The following is a description of a gene set: The chemical reactions and pathways involving urate, the anion of uric acid, 2,6,8-trioxypurine, the end product of purine metabolism in certain mammals and the main excretory product in uricotelic animals. Mouse Gene Set: GOBP_URATE_METABOLIC_PROCESS studied in species Mus musculus, and this is the list of marker genes: G6pc1, Slc16a9, Gckr, Carmil1, Prps1, Urad, Abcg2, Slc22a12, Uox, Abcg3, Slc17a1, Slc17a3, Slc2a9, Urah, Spp1, Pnp